Given this list of marker genes CTSS, THRB, GCLM, TOMM70 (NCBI Gene Id 9868), RDX, MED1, ABCB1, SLC26A5, C2, CAB39, F7, SLC34A1, GCLC (NCBI Gene Id 2729), GHSR, INHBB, HPN, CTSH, GBA1, CTSL, CTSB, HES1, BRD8, here is a description of the gene set: Human Gene Set: GOBP_RESPONSE_TO_THYROID_HORMONE A change in state or activity of a cell or an organism (in terms of movement, secretion, enzyme production, gene expression, etc.) as a result of a thyroid hormone stimulus. species: Homo sapiens